Given this list of marker genes BOLL, SELL, SLC17A9, DGKA, TDRKH, FNTB, ACTN1, CD2AP, SPACA1, MYCBP2, LYRM7, SEMA4B, WLS, CRYL1, KLHDC1, GRIA3, SI, IL6ST, ADGRG5, RAPGEF4, DNAJC7, ALS2CL, PPCDC, AFP, TREML2, TGFBR3, MIGA1, ST8SIA1, DZIP1, PELI1, RAB3IP (RAB3A interacting protein), SSBP2, MAP3K3, USP53, CEP68, NIPAL1 (NIPA like domain containing 1), ABRAXAS1, SELE, SLC6A19, CHD4, SCML4, ST6GAL1, RCN2, ABCD3, LRRC1, XKRX, TOM1L2, IFNGR2 (interferon gamma receptor 2), IL6R, SCAPER, IGFBP4, CNN3, BCOR, DPP4, RFLNB, GIGYF2, USP28, TRIB2, LARP1, LDLRAP1 (NCBI Gene Id 81862), HMGCS1, OVGP1, HDAC4, TET1, WDR43, POLR1E, DKC1, DCAF6, QSER1 (glutamine and serine rich 1), TPCN1, TLR1, MTSS1, MIR20A, MYC, TTC28, FCHSD2, SESN1, ABCE1, MAGI3 (membrane associated guanylate kinase, WW and PDZ domain containing 3), CCR9, NEDD4L, ADCY6, ATM, LRIG1, ID3, TASOR2, AGK, AP1AR, ARHGAP15, IRS2, FAM78A, GART, ARID4A, PRRG1, LRP6, DAPL1 (death associated protein like 1), UTP25, CNGA1, HSPBAP1, RNF167, PRMT3, SLC49A4, DDC, ICE2, FOXK1, INSR, WDR77, LZTFL1, USP32, MGST2, SH3BP5, MDN1, ELK4, SCMH1, METTL8, TNFSF8, IGF1R, TMIE, CEP97, FILIP1L, RPS26 (ribosomal protein S26), AMPD1, ANGPTL1, TRAT1, IGFLR1, ACVR2A, IFT80, CRIPTO, BTLA, PTK2, EML5, TTC27, RAI1, PDK1, ITGAE, SLC25A27, SLC16A5, PATJ, CRLF3, ABCA1, METTL9, RNF122, RAPGEF6, ZBTB20, CCR7, PCGF6, SNHG1, IKBKE, BACH2, N4BP2, LMBR1, ZNRF1, TTC3, PLEKHO1, IZUMO1R, TOP2B, SESN3, RRAS2, CHST15, RGS10, NRROS, TFPI, RAMP1, LDHB, SFMBT2, DSE, NSG2, TENT5A, here is a description of the gene set: from publication Ng SY, Yoshida T, Zhang J, Georgopoulos K (PMID 19345118) Genes down-regulated in hematopoietic stem cells versus megakaryo-erythrocyte progenitors. Human Gene Set: GSE15330_HSC_VS_MEGAKARYOCYTE_ERYTHROID_PROGENITOR_DN Regulation of lineage potential and transcriptional priming by Ikaros. New insight is provided into a bivalent regulation of lineage priming in the HSC and its lympho-myeloid restricted progeny the LMPP by the lymphoid lineage-determining factor Ikaros Whereas Ikaros is responsible for the activation of a cascade of lymphoid expression programs and for the establishment of lymphoid potential from the HSC to the LMPP it is also responsible for the repression of stem cell and erythroid genetic programs that are incompatible with further lineage restrictions emanating from the LMPP species: Homo sapiens